The following is a description of a gene set: Human Gene Set: HP_ABNORMALITY_OF_THE_UTERUS An abnormality of the uterus. Abnormality of the uterus species: Homo sapiens, and this is the list of marker genes: KIF14, ALG9, NRAS, IFT80, CDC73, TAC3, GLI3, GNB2, CDH1, PLA2G2A, SMC1A, KLLN, FLI1, SMAD2, CTNNB1, SPIDR, TGFBR1, PALB2, NSMF, CYP11B1, DYNC2H1, FGF10, FGFR1, SPECC1L, FGFR2, HNF1B (NCBI Gene Id 6928), COL5A1, MCC, COQ6, IRF6 (interferon regulatory factor 6), TP53, INTU, RBM8A, MSH2, FANCL, FANCM, GNRH1, TP63, SDHC, BAX, BMPR1A, NIPBL, TAF6, HYLS1, FANCD2, SDHB, LRP2, MRPS22, FANCE, FANCF, FOXL2, COL1A1, ESR1, GREM1, SEC23B, CPLX1, NUP107, NDP, PIGG, SEMA4A, TBX3, BRIP1, MINPP1, BRCA2, FGFRL1, DHX37, DCAF17, COL5A2, AURKA, SOX9, NDUFB11, MNX1, DLC1, ARVCF, NHLH2, WNT7B, BMPR1B, ARID1B, RPS20, HDAC8, PLG, THOC6, WDR35, CHEK2, TXNDC15, FH, SDHD, SMARCB1 (NCBI Gene Id 6598), NTHL1, DUSP6, APC, PMS2, RPS6KA3, MID1, SMAD3, SRY, HS6ST1, PPP2R3C, PTEN, MSH4, RAD21, SEC24C, TGFB3, PHGDH, PMS1, FGF8, GATA3, BUB1B, BRCA1, SF3B4, CTBP1, FIGLA, AKT1, NELFA, H19, PTPN12, MKS1 (MKS transition zone complex subunit 1), GNRHR, BRAF, REST, FRAS1, GRIP1, TBX1, KISS1, DIS3L2, ESCO2, POR, FGFR3, ADH5, CCND1, BNC1, MSH5, DYNC2I1, STK11, JMJD1C, CHD7, SOHLH1, PTPRJ, COL4A5, RREB1, B3GLCT, WDR11, MLH3, TLR2, KRAS, HOXA13, COX7B, PPP2R1A, CCNQ, NR5A1, NAB2, NSD2, PROKR2, BMP15, GATA2, UBE2T, GPC3, TGFB2, NIN, MAD1L1 (mitotic arrest deficient 1 like 1), MSH3, CLPP, FGF17, MAD2L2, PROK2, POLR3H, TNXB, POLD1, AXIN2, IPO8, EPCAM, FANCC, DHCR7, FZD2, MLH1, WNT4, AR, KISS1R, CHRM3, PSMC3IP, BRD4, FOXF1, DCC, ERAL1, COL4A6, STAT6, XRCC2, TOE1, PAX6, ZSWIM7, STRA6, PDGFRL, DYNC2I2, SALL1, RFWD3 (ring finger and WD repeat domain 3), ELN, RARB, FANCA, ERCC4, SETBP1, POLE, RAD54B, LARS2, HPS6, SMC3, SRC, CYB5A, COL3A1, RIPK4, POU6F2, GREB1L, ITGA8, TACR3, ATM, CYP11A1, LZTR1, FANCG, NF2, C14orf39, BUB1, PIGN, AXIN1, SLC6A17, MUTYH, SOX11, WT1, EP300, RAD51, TRIM28, TGFBR2, MYRF, DACT1, PPP1R12A, FANCI, TRIP13, COMT, DHH, FLCN, RAD51C, CDKN1B, FSHR, HIRA, LETM1, PIK3CA, SLX4, UFD1, HCCS (holocytochrome c synthase), GP1BB, CYP17A1, MSH6, FREM2, SPRY4, FANCB, WNT7A, USF3 (upstream transcription factor family member 3), CXCR4